Given this list of marker genes Twsg1, Mir3960, Mef2c, Chrd, Fgfr1, Mir338, Vegfa, Hoxa2, Wnt7b, Smoc1, Tnfaip6 (NCBI Gene Id 21930), Sox11, Scube3, Twist1, Mir217, Mir30c-2, Ostn, Fbxo5, Ranbp3l, Tent5a, Crim1, Erfe, Prkaca, Apc, Mir204, Bmpr1a, Fbn2, Bmp7, Acvr2a, Cthrc1, Cd276, Rorb, Fgf2, Men1, Fgf23, Tmem53, Tnf, Dnai3, Gli3, Lmna, Bmp6, Zfp932, Prkd1, Ddx5, Trp63, Smad5, Sox2, Ipo7, Il6, Limd1, Atraid, Mir137, Igf1, Mir188, Ptk2, Cebpb, Jag1, Gnas, Tnn, Notch1, Nbr1, Nfatc1, Tcirg1, Bmp4, Cebpa, Cdk6, Ahr, Tmem64, Bmp2, Ilk, Acvr1, Atf4, Ptch1, Il6st, Ccn4, Axin2, Ffar4, Nppc, Fam20c, Zhx3, Wwtr1, Acvr2b, Mir23a, Msx2, Jund, Nell1, Hemgn, Pparg, Sfrp2, Gdpd2, Hdac7, Sox9, Ski, Gsk3b, Cited1, Nog, Bmpr2, Ctnnbip1, Bmpr1b, Id2, Sema4d, Mir205, Dlk1, Twist2, Rassf2, Id3, Mir210, Trpm4, Ifitm1, Gli1, Fzd1, Lrp5, Runx2, Ltf, Riox1, A430033K04Rik, Ucma, Hdac8, Mir135a-1, Mir133a-1, Id1, Ptger4, Prmt3, Ccn1, Grem1, Mir30c-1, Tmem119 (transmembrane protein 119), Lrp3, Bambi, Areg, Dlx5, Sfrp1, Snai2, Ifi204, Hdac5, Smad3, Wnt4, Hey1, Igfbp5 (NCBI Gene Id 98676), Gdf10, Tob1, Mir133a-2, Scube2, Mir214, Ppp3ca, Smad1, Esrra, Ctnnb1, Clic1, Vegfc, Noct, Suco, Cebpd, Wnt3, Npnt, Hand2, Wnt10b, Smad6, Ddr2, Fndc3b, Fermt2, Hdac4, Rest, Pdlim7, Yap1, here is a description of the gene set: Mouse Gene Set: GOBP_REGULATION_OF_OSTEOBLAST_DIFFERENTIATION Any process that modulates the frequency, rate or extent of osteoblast differentiation. studied in species Mus musculus